The following is a description of a gene set: electronically inferred by orthology from the curated human pathway This event has been computationally inferred from an event that has been demonstrated in another species.<p>The inference is based on the homology mapping from PANTHER. Briefly, reactions for which all involved PhysicalEntities (in input, output and catalyst) have a mapped orthologue/paralogue (for complexes at least 75% of components must have a mapping) are inferred to the other species. Reactome Pathway: Ribosomal scanning and start codon recognition part of: Cap-dependent Translation Initiation studied in species Mus musculus, and this is the list of marker genes: Eif3b (NCBI Gene Id 27979), Rps28, Rps9 (NCBI Gene Id 76846), Fau, Rps25, Rps19, Eif3i, Rps24, Rps5, Rps8, Eif3j2, Rps3a1, Eif3g, Rps15, Eif2s3x, Eif3d, Eif3f, Rps4x (ribosomal protein S4, X-linked), Rps17, Eif4a1, Rps27l, Rps26, Eif1ax, Rps7, Rps11, Rps12, Eif4a2, Rps23, Rps18, Eif3e, Rps13, Rps6, Eif3k, Rps20, Rps2, Rps10